The following is a description of a gene set: Human Gene Set: GOMF_UNMETHYLATED_CPG_BINDING species: Homo sapiens Binding to uan nmethylated CpG motif. Unmethylated CpG dinucleotides are often associated with gene promoters., and this is the list of marker genes: TLR9, CXXC1, KMT2B, KDM2B, FBXL19, KMT2A, DNMT3A, KDM2A, MBD1